Given this list of marker genes Ogg1, Rnf138, Rnf138rt1, Slx4, Rad52, Helq, Rbbp8, here is a description of the gene set: species: Mus musculus Repair of a DSB made between two repeated sequences oriented in the same direction occurs primarily by the single strand annealing pathway. The ends of the break are processed by a 5' to 3' exonuclease, exposing complementary single-strand regions of the direct repeats that can anneal, resulting in a deletion of the unique DNA between the direct repeats. Mouse Gene Set: GOBP_DOUBLE_STRAND_BREAK_REPAIR_VIA_SINGLE_STRAND_ANNEALING